The following is a description of a gene set: species: Homo sapiens A congenital malformation with a cleft (gap or opening) in the face. Tessier cleft Human Gene Set: HP_TESSIER_CLEFT, and this is the list of marker genes: ALX1, DYNC2I1, COLEC10, POLR1C, SF3B2, WDR35, SPECC1L, FRAS1, IFT80, POLR1D, DYNC2H1, TCOF1, DYNC2I2, ALX4, EVC, POLR1B, ZSWIM6, RIPK4, EVC2